The following is a description of a gene set: Human Gene Set: HP_ABNORMAL_MENINGEAL_MORPHOLOGY Abnormal meningeal morphology studied in species Homo sapiens An abnormality of the Meninges, including any abnormality of the Dura mater, the Arachnoid mater, and the Pia mater., and this is the list of marker genes: CDKN1B, ARID2, ITPR1, GP1BB, OTUD5, EIF3F, DNAJC19 (DnaJ heat shock protein family (Hsp40) member C19), SDHC, RIPPLY2, COL18A1, MN1, CSPP1, WDR19, GMPPB, KCNC2, STAG2 (NCBI Gene Id 10735), GLI2, ZFX, CPLANE1, IFT140, PKD2, DISP1, KIAA0586, WLS, SMAD2, WNT7A, RTTN, CREBBP, PUS3 (NCBI Gene Id 83480), SHANK3, TGFB2, PTCH1, CRPPA, TGFB3, ALG5, SMARCB1, NRAS, NARS1, ALG9, AXIN1 (NCBI Gene Id 8312), DLL1, SC5D (NCBI Gene Id 6309), TMEM216, DNAJB11, CCDC22, KDM1A, NDE1, SCN1A, NTHL1 (NCBI Gene Id 4913), ATP6AP1, SDHB, WRN, PDGFB, LOX, KRAS, MYH11, SHH, RNU4-2, FOXC2, RASA1, WAC, LARGE1, COMT, INPP5E, SMC1A, AHDC1, FGFR2, EIF4A2, MYLK, ZSWIM6, ARVCF, NODAL, FBN1, SNRPB (NCBI Gene Id 6628), GNAS, HEY2, TGFBR2, VANGL1, TERT, PPP2R5D, KRIT1, LFNG, ADAT3, MAT2A, MBD4 (NCBI Gene Id 8930), EBP, SMO, PIK3CA, ELN, RREB1, DHCR7, LMNA, TBX1, GPSM2, TGIF1, BAP1, TMEM237, CTCF, SIX3, CHEK2, TTR, SH2B1, NRCAM, CRIPTO, MFAP5, BICC1, SLC30A9, NEK1, SMAD3, B3GALNT2, SON, POMT1, FGF8, PUF60, FKTN, SCAF4, FOXE3, ABCC6, NOTCH3, HES7, OFD1, XPNPEP3, PI4KA, GANAB, DDR2, COL11A1, ZIC2, PTEN, NSD1, UFD1, THSD4, SACS, PLCH1, LZTR1, KLLN, HRAS, GAS1, SMAD4, ZNFX1, TRAF7, CCM2, ARMC5, GJA1, RNU4ATAC, SCN2A, CDKN1A, STT3A (NCBI Gene Id 8071), CDON, PTCH2, FGFR1, COQ6, PDCD10, JMJD1C, SMARCE1, AKT1, FOXH1, CEP290, DLL3, USF3, EFEMP1, PLK4, ACTA2, POMT2, EP300, NF1, STIL, PDGFRB, SDHD, ATN1, TGFBR1, PKD1, POMGNT1, KANSL1, RAB3GAP2, MEN1, FKRP, SEC24C, SEC23B, PAX3, CDKN2C, ALKBH8, SUFU, NF2, PRKG1, CDKN2B, HIRA, MESP2, DENND5A